Given this list of marker genes RGL2, AOPEP, TFAP2A, CDKN1A, RAC1, IGFBP5, SERPINB2, RAB5B, TP53, HBS1L, CDKN2B, ING1, IGFBP3, THBS1, MDM2, IGFBP7, SERPINE1, VIM, CXCL14, NME2, IGFBP2, F3 (coagulation factor III), RBL2, RABGGTA, MMP1, TNFAIP2, IRF7, HPS5, IGSF3, CCND1, FILIP1L, NDN, CDKN1C, CDKN2A, EIF2S2, S100A11, OPTN, CITED2, RAB31, CREG1, SMPD1, CRYAB, RRAS, CDKN2D, IGFBP4 (NCBI Gene Id 3487), SPARC, GSN, IGFBP6, TES, CD44, ESM1, ALDH1A3, FN1, TNFAIP3, SOD1, CYP1B1, CLTB, TSPYL5 (NCBI Gene Id 85453), MAP2K3, IGFBP1, SMURF2, RHOB, IRF5, CCN2, RAB13, ISG15, IFNG, STAT1, HTATIP2, IFI16, TGFB1I1, PEA15, NRG1, HSPA2, MAP1LC3B, GUK1, COL1A2, here is a description of the gene set: Human Gene Set: FRIDMAN_SENESCENCE_UP from publication Fridman AL, Tainsky MA (PMID 18711403) studied in species Homo sapiens Bypassing cellular senescence and becoming immortal is a prerequisite step in the tumorigenic transformation of a cell. It has long been known that loss of a key tumor suppressor gene, such as p53, is necessary, but not sufficient, for spontaneous cellular immortalization. Therefore, there must be additional mutations and/or epigenetic alterations required for immortalization to occur. Early work on these processes included somatic cell genetic studies to estimate the number of senescence genes, and microcell-mediated transfer of chromosomes into immortalized cells to identify putative senescence-inducing genetic loci. These principal studies laid the foundation for the field of senescence/immortalization, but were labor intensive and the results were somewhat limited. The advent of gene expression profiling and bioinformatics analysis greatly facilitated the identification of genes and pathways that regulate cellular senescence/immortalization. In this review, we present the findings of several gene expression profiling studies and supporting functional data, where available. We identified universal genes regulating senescence/immortalization and found that the key regulator genes represented six pathways: the cell cycle pRB/p53, cytoskeletal, interferon-related, insulin growth factor-related, MAP kinase and oxidative stress pathway. The identification of the genes and pathways regulating senescence/immortalization could provide novel molecular targets for the treatment and/or prevention of cancer. Genes up-regulated in senescent cells.